Given this list of marker genes RPL18, RPL5, RHAG, RPL15, RPS19, RPL11, LPIN2, HEATR3, RPS20, RPL8, RPL35, DUT, RPS28, DHFR, ADA2, HBB, TRNT1, RPS7, GLRX5, RPS29, SLC11A2, SLC25A38, LARS2, RACGAP1, RPS24, ABCB6, RPL35A, STEAP3, SBDS, RPS26, PIEZO1, LIG1, RPL27, CBLIF, ANKRD11, RPL9, SPTB, MDM4, GTF2E2, NHLRC2, KCNN4, TMPRSS6, RPS15A, RPL26, RPS17, TERC, EFL1, TSR2, SAMD9L, GATA1, SAMD9, RPS10, DNAJC21, RPL31, MMADHC, RPS27, POT1, ETV6, TERT, SLC4A1, MTRR, KIF23, TINF2, here is a description of the gene set: Human Gene Set: HP_ABNORMAL_MEAN_CORPUSCULAR_VOLUME Abnormal mean corpuscular volume A deviation from normal of the mean corpuscular volume, or mean cell volume (MCV) of red blood cells, usually taken to be 80 to 100 femtoliters. species: Homo sapiens